The following is a description of a gene set: Neighborhood of PTPRU protein tyrosine phosphatase, receptor type, U in the GCM expression compendium Neighborhood of PTPRU Human Gene Set: GCM_PTPRU studied in species Homo sapiens, and this is the list of marker genes: STAT4, PTPRU, CHRM5, CHIC1, ELK4, SLC18A1, FUT2, SUPT4H1, TEC, FCGR2A, COL14A1, MPP2 (MAGUK p55 scaffold protein 2), ITSN1, GHRHR, TMEM106A, IFNA21, FHL3, APOC3, ADCYAP1, CSN3, AVPR1B, CHRNE, PRKCA, SSTR3, KRT35, POP1, ZNF8, MVK, ERCC4, ERV3-1, TAF1, CD8B, AANAT, FEV, KRT12, FABP3, CSPG4, GH2 (NCBI Gene Id 2689), KRT83, MYH7, CCR9, SLC30A3, VPS72, GABRQ, SLC14A2, POLR1HASP, NDUFA1, CDH5, HMGA2, GCK, SLC17A2, KRT86, BNIP1, KCNA6, SMARCD1